Given this list of marker genes ALG13, ALG14, here is a description of the gene set: part of: Diseases associated with N-glycosylation of proteins Reactome Pathway: Defective ALG14 causes ALG14-CMS studied in species Homo sapiens UDP-N-acetylglucosamine transferase subunit ALG14 homolog (ALG14) forms a complex with ALG13 protein and is required for the addition of the second N-acetylglucosamine (GlcNAc) to the lipid linked oligosaccharide (LLO) intermediate (GlcNAcDOLDP). Defects in ALG14 can cause congenital myasthenic syndrome (ALG14-CMS), which is due to a defect in neuromuscular signal transmission. The most commonly affected muscles include proximal limb muscles. Mutations causing ALG14-CMS include p.P65L and p.R104*.